The following is a description of a gene set: Mouse Gene Set: HALLMARK_IL6_JAK_STAT3_SIGNALING species: Mus musculus from publication Howe DG, Blake JA, Bradford YM, Bult CJ, Calvi BR, Engel SR, Kadin JA, Kaufman TC, Kishore R, Laulederkind SJF, Lewis SE, Moxon SAT, Richardson JE, Smith C (PMID 30224793) Mouse genes annotated to HALLMARK_IL6_JAK_STAT3_SIGNALING based on orthology mappings provided by the Alliance Genome Consortium, and this is the list of marker genes: Cxcl2, Tnfrsf1a, Ifngr2, Acvrl1, Il6, Il9r, Cbl, Dntt, Il4ra, Tlr2, Il6st, Inhbe, Il13ra1, Ebi3, Irf1, Cd38, Jun, Il7, Il3ra, Reg1, Pdgfc, Ltb, Socs1, Il1r1, Il1r2, Ccl7, Il17ra, Myd88, Acvr1b, Tnfrsf21, Cntfr, Ifnar1, Csf3r, Cd14, Cxcl11, Irf9, Pf4, Ifngr1, Osmr, Cxcl9, Il18r1, Tnfrsf1b, Cd9 (NCBI Gene Id 12527), Crlf2, Grb2, Cd44, A2m, Il10rb, Stat1, Ptpn1, Hmox1 (heme oxygenase 1), Itga4, Cxcl13, Ptpn2, Csf2, Ltbr (NCBI Gene Id 21932), Ptpn11, Cd36, Stam2, Itgb3, Hax1, Fas, Csf1, Stat3, Bak1, Cxcl10, Tnfrsf12a, Il17rb, Map3k8, Lepr, Pla2g2a, Tgfb1, Stat2, Tyk2, Socs3, Il1b, Ccr1, Pik3r5, Tnf, Il2rg, Il12rb1, Il2ra, Csf2ra, Il15ra, Pim1